Given this list of marker genes Tbccd1, Golga2, Dab1, Cdc42, Arcn1, Arhgap21, Stk11, Nherf1, Ywhaz, Copg1, Ripor1, Pdcd10, Stk25, Hook3, Uvrag, here is a description of the gene set: Any process in which the Golgi is transported to, and/or maintained in, a specific location within the cell. species: Mus musculus Mouse Gene Set: GOBP_GOLGI_LOCALIZATION